Given this list of marker genes Slc25a3, Gpx4, Sap18, Nabp1, Ranbp1, Gramd2b, Ifi208, Cops4, Wars1, Gadd45g, Flnb, Itpr1, Isg15, Psma4, Zc3h15, H2-D1, Sbno2, Rnf157, Tbcc, Lmna, C1qbp (NCBI Gene Id 28127), Apobec3, Dnaja1, Psma2, Arpp19, Ubl5, Zfp1, Casp8ap2, Psma1, Atp5f1d, Mif, Tex2, Pdia6, Eif5a (eukaryotic translation initiation factor 5A), Sdf4, Uba7, Chmp4b, Dtx3l, Hif1a, Irf7, Pmepa1, Slfn1, Ssr3, Tap1, Ly6e, Sipa1l1, Hspa9, Igtp, Prdx2, Ifngr1, Isg20, Ehd1, Trim30d, Sp110, Ttc39c, Krtcap2, Bbx, Tcerg1, Atp5mk, Rtp4, Rpia, Gstp1, Daxx, Prdx6 (peroxiredoxin 6), Donson, Smchd1, Ncl, Cebpb, Hopx, Wnk1, Tpm3, Cfdp1, Manf, Ifi27l2a, Arpc3, Por, Mrfap1, Tmbim6, Psmd7, Helz2, Gtf3c6, Ldha, Psmb9, Trim21, Timm50, Nmi, Prdx1, Gbp2, Lsm12, Pkm, Slirp, Isy1, Gtf3c1, Trib2, Elavl1, Sec23b, Prmt1, Mrpl23, Ndufb2, Nab1, Plaat3, Sub1, Slfn8, Nfkb2, Ube2j2, Naa20, Dnaja2, Ssb, Psmd3, Socs3, H2-T22, Rab10, Iigp1, Tcof1, Bcl3, Psmb10, Calr, Akt2, Ostf1, Stam2, Ramp3, Gpr183, Taf15, Arid5b (AT-rich interaction domain 5B), Crybg1, Mvp, Crem, Mpc1, Aldoa, Adar, Stat2, C1qtnf12, Wdr83os, Ksr1, Psme1, Noc2l, Cd2 (CD2 antigen), Erh, Stat1, H2-Q4, Jak2, Irf8, Dph3, Mxd1, Zup1, Mlec, Ogfr, Psmb6, Morf4l2 (mortality factor 4 like 2), Hspa8, Gbp3, Ifitm2, Emd (emerin), Ran, Ly6a, Dad1, Tuba4a, Ddx24, Mrpl52, Map2k3, Golt1b, Slc25a19, Gpr18, Hspa5, Stip1, Myl12b, Eprs1, Mllt6, Emb, Syngr2 (synaptogyrin 2), Calhm6, Stat3 (signal transducer and activator of transcription 3), Hsp90ab1, Ndufb4, Jund, Zdhhc2, Gbp7, Mdh1, Ifit3, Ahsa1, Ptma, Bsg, Zeb1, Ddx60, Xaf1, Lgals3bp, Ppa1, Sin3b, Tapbpl (TAP binding protein-like), Bzw2, Psma7, Eif5b, Pdlim1, Iqgap2, Btbd9, Psenen, Lsm6, Aftph, Ifi35, Oas1a, Tubb4b, Cox5a, Trim30a, Slfn5, Serpinb6b, Idnk, Il2rb, Park7, Il21r, Prpf31, Gfus, Uqcc2, Psmb8, Eloc, Parp9, H2az1, Cycs, Tnfrsf4, Cltb, Tspan5, Cd86, Socs1, Herc6, Psme2, Ifih1, Tapbp, Itpk1, Mif4gd, Pcbp1, Pdzk1ip1, Ier3ip1 (NCBI Gene Id 66191), Samd9l, Ptpn1, Irgm1, Ddx42, Phf11b, Cd53, Dgat1, Atp2b4, Samhd1, Psmc4, Eif2ak2, Actg1, B2m, H2-T23, Nup98, H2-K1, Flot1, Gbp4, Dctpp1, Tnfrsf9, Skap2, Tnfrsf18, Bbip1, Hsp90aa1, Copb2, Gbp5, Ndufs5 (NCBI Gene Id 595136), Gadd45b, Got1, Rnf114, Zbp1, Ifit1, Foxp3, Grb2, Tap2, Pa2g4, Gapdh, Lamp2, Psmb5, Strap, Irf9, Eif1, Phlpp1, Bst2, Nudc, Irf1, Batf, Nop56, Exosc3, Eny2, Usp18, Ube2l6, Kif5b, Abcb1a, Fth1, Ifi206, Cep57l1, Ubb, Fkbp4, Cct8, Laptm4a, Psma5, Ifi47, Stat5a, Pgam1 (NCBI Gene Id 68006), Eif4a1, Ifi209, Snrpg, Oas3, Eif1ax, Epsti1, Odc1, Parp14, Polr2f, Rnf213, Cars1, Xlr4b, Trim28, Rbms2, Crlf2, here is a description of the gene set: studied in species Mus musculus Cytokines mediate cell-cell communication in the immune system and represent important therapeutic targets. A myriad of studies have highlighted their central role in immune function, yet we lack a global view of the cellular responses of each immune cell type to each cytokine. To address this gap, the authors created the Immune Dictionary, a compendium of single-cell transcriptomic profiles of more than 17 immune cell types in response to each of 86 cytokines (>1,400 cytokine-cell type combinations) in mouse lymph nodes in vivo. A cytokine-centric view of the dictionary revealed that most cytokines induce highly cell-type-specific responses. For example, the inflammatory cytokine interleukin-1β induces distinct gene programmes in almost every cell type. A cell-type-centric view of the dictionary identified more than 66 cytokine-driven cellular polarization states across immune cell types, including previously uncharacterized states such as an interleukin-18-induced polyfunctional natural killer cell state. from publication Cui A, Huang T, Li S, Ma A, Pérez JL, Sander C, Keskin DB, Wu CJ, Fraenkel E, Hacohen N (PMID 38057668) Genes positively differentially expressed in cell type: Treg upon treatment with cytokine: IL-36α in mouse lymph nodes in vivo. Mouse Gene Set: CUI_TREG_IL36A_RESPONSE_UP